The following is a description of a gene set: studied in species Homo sapiens Human Gene Set: GSE13411_IGM_MEMORY_BCELL_VS_PLASMA_CELL_UP Genes up-regulated in comparison of IgM-memory B cells versus plasma cells. from publication Good KL, Avery DT, Tangye SG (PMID 19124732) Enhanced secondary Ab responses are a vital component of adaptive immunity, yet little is understood about the intrinsic and extrinsic regulators of naive and memory B cells that results in differences in their responses to Ag. Microarray analysis, together with surface and intracellular phenotyping, revealed that memory B cells have increased expression of members of the TNF receptor, SLAM, B7 and Bcl2 families, as well as the TLR-related molecule CD180 (RP105). Accordingly, memory B cells exhibited enhanced survival, proliferation and Ig secretion, as well as entered division more rapidly than naïve B cells in response to both T-dependent and T-independent stimuli. Furthermore, both IgM and isotype switched memory B cells, but not naïve B cells, co-stimulated CD4+ T cells in vitro through a mechanism dependent on their constitutive expression of CD80 and CD86. This study demonstrates that upregulation of genes involved in activation, co-stimulation and survival provides memory B cells with a unique ability to produce enhanced immune responses and contributes to the maintenance of the memory B cell pool., and this is the list of marker genes: ZNF573, NECAP2, ABCD4, IQSEC1, SNX10, FRAT1, ATP8A1, DENND5A, NKRF, SNX29P2, SCAF4, GNPDA1, ASH2L, PCDHGC3, NFRKB, RAB5B, DIAPH1, ELMO1 (NCBI Gene Id 9844), TBC1D13, ARHGEF6 (NCBI Gene Id 9459), KLF4, SOS2, ARL2, KBTBD2, HLA-DRB6, JADE3, ZNF589, PTPRK, PBX3, PXDC1, ARL4C, B4GALT5, CD72, CD19, TRIM13, TRDMT1, HSF2, SPAG7, PARP8, CHD9, ALOX5AP, MTA1, CD74, ZNF93, MCCC2, ZFYVE26, UPF1, KDM6A (NCBI Gene Id 7403), CD22, PARP12, TRBC1, ARHGAP17, RBCK1, REPIN1, PRAMEF10, AMFR, COQ8A, PTPN18, USP24, TMEM185B (NCBI Gene Id 79134), ZFP37, NLRP1, TARBP1, AGO1, SATB1, TGFBR2, VSIG10, SIK3, MYD88, TRAF3IP2, ARHGAP25, APOH, TSGA10, NUDT3, INPP5A, AKAP10, RAB11FIP1, ITPK1, ZNF136, QRSL1, LAT2, BACE2, HCK, EXOSC5, RNF220, VPS8, ATP6V0E2, N6AMT1, KDM4B, IFITM2, WNT6, DAAM1, GCC1, PMS2P2, SPG11, LBH, DLST, SEPTIN9, ITPKB, PEX26, P2RY14, BTN2A1 (NCBI Gene Id 11120), ARHGAP24, SLC25A37, TTC27, RPS18, PRKX, DEK, TMX4, VCL, EVL, CEP72, AIM2, BACH2, PIKFYVE, EXT2, CNTRL, RBM38, TNFRSF10B, HOPX, JARID2, ALOX5, RCL1, WDR19, CRIP1, AUTS2, ST3GAL5, RPL10, NAA40, STAT5B, SNX17, PIGA, ZNF665, ESR2, ZEB2, CTNNBL1, RPS12, BPTF, ATAD2B, WDR91 (WD repeat domain 91), JADE2, RPL30, SPOUT1, RPS11, SLC25A36, ANO3, PFDN5, EIF2D, MZF1, DDX60, USP39, KLHL2, IL24, CHD1, CRTC3, PIGZ, IL16, WASF2, ZNF23, TNFSF9, RASSF2, C14orf132, HOXA5 (homeobox A5), RPL41, PLS3, TNFSF13, MGRN1, HBBP1, ZNF430, CLK2, CAPG, NDRG3, DNAJC11 (DnaJ heat shock protein family (Hsp40) member C11), PPM1F, CORO1A (NCBI Gene Id 11151), TIMM22, CCDC92, PLAG1, PTPRG, SMIM14, DGKA, ZNF264 (NCBI Gene Id 9422), INPP5D, PCDH8, MARF1, SCN3A, HLA-DQA1, TPT1, ARHGEF7, DET1, RUNX3, MTHFSD, RABGAP1, TDRD7, TP53TG1, PIBF1, OXLD1, RAP2C